Given this list of marker genes PSMD13, NUMB, CUL1, PRKACA, SEM1, PSMA5, PSMB5, SUFU, PSMD2 (proteasome 26S subunit ubiquitin receptor, non-ATPase 2), PSMB3, PSMB7 (NCBI Gene Id 5695), PSMD7, PSMB2, PSMC1, UBC, PSMC2, GLI1, ITCH, PSMB4, BTRC, PSMD12, PSMC6, PSMD8, PSMC4, SKP1, UBB (ubiquitin B), PSMA2, PSMA3, PSMD3, PRKACB, PSMD11, PSMC3, RPS27A, RBX1, PSMA1, PSMA4, PSMB6, PSMA7, PSMD1, ADRM1, PSMD14, PSMD6, UBA52, PSMA6, PSMB1, PSMC5 (proteasome 26S subunit, ATPase 5), PRKACG, here is a description of the gene set: Degradation of GLI1 by the proteasome species: Homo sapiens Human Gene Set: REACTOME_DEGRADATION_OF_GLI1_BY_THE_PROTEASOME